The following is a description of a gene set: A general defect of GF K/BxN T cell proliferation response toward antigen motivated us to look for the impairment in GF K/BxN T cells that might leads to the low Ab production and reduced disease phenotype seen in GF K/BxN mice. To find the difference between GF and SPF K/BxN T cells in a broad and non-biased fashion, we performed gene-expression profiling of these cells using microarrays. studied in species Homo sapiens Human Gene Set: GSE22140_HEALTHY_VS_ARTHRITIC_GERMFREE_MOUSE_CD4_TCELL_DN from publication Wu HJ, Ivanov II, Darce J, Hattori K, Shima T, Umesaki Y, Littman DR, Benoist C, Mathis D (PMID 20620945) Genes down-regulated in CD4 T cells under germ free conditions: healthy versus arthritis (KRN model)., and this is the list of marker genes: P2RX4, BLVRB, ZFHX3, ILF2, PAF1, STAB1, INSIG1, PTOV1, ATP6V0D1, IRF1 (NCBI Gene Id 96501), C15orf39, EZR (NCBI Gene Id 7430), NAPA, TECR, PIM1, HOMER3, TNF, ZNF134, ABHD14A, FURIN, CD99, SLC7A11, LMNA, BATF, PLTP, GEM, S100A4, LGMN, BCAP31, HIVEP2, PHLDB1, SRSF2, GOSR2, MIR22HG, CCL3, HSPA1A, TNFAIP2, PDGFB, PPP1R15A, TRAF1, IL1B, TIMP2, RBM4, MAP4K4, NPC1, ZNF200, LCP2 (lymphocyte cytosolic protein 2), IER3, CCL8, RNASE1, IFI44, UAP1, FOLR2, OASL, SLC3A2, RPN1, ELOC, RPN2, CRIP1, IL7R, TGFA, SERPINB2, VSIG4, TUBB2A, RNF19B, TUBB4B, GPR107, FYN, ABL2, SH3BP5, CLIC1, PTX3, TP53BP2, TGFBI, ADAM19, ATRN, APLP2, PPIF, CLEC11A, SNN (stannin), DNAJC8, AK4, MTSS1, CCR1, ICAM1, COMT, HMOX1, CDKN1A, LGALS1, F13A1, HSP90B1, STX2, SLC7A8, NID1, TEX30, SDS, TLR2, RPS24, CCL4, DUSP5, SERPINE1, CTSL, PNP, TRIB1, STX4, WTAP, DNMBP, BIN1, DOCK10, THBS1, CTSZ, UBE2H, TPD52L2, EIF4A3, TNFRSF9, MRC1, PMAIP1, TCP1, CXCL1, CPQ, APBB3, NCOR2, TIMP1, PRPF4, CD47 (NCBI Gene Id 961), P2RX7, ATP8A1, BTG2, VNN2, GPNMB, TXNRD1 (NCBI Gene Id 7296), TUBB4A, MAP2K3, MX1, KRT10, ELL2, MYO7A, CCL7, TRIM25, IFIT2, SH3GL1, EMP1, MAN1A1, KLF6, YWHAZ, MSC, VASP (vasodilator stimulated phosphoprotein), HMGA1, DUSP2, TEX261, FCGBP, UPP1, TNFSF14, NQO1 (NCBI Gene Id 4834), FUS, LAIR1, RGS16, SERTAD2, OAS2, RENBP, GNA15, SERPINB8, KANK1, CLN3, CREM, CTSK, PMP22, RBMS1, CALM3, HLX, BCAT1, DENND4A, RGS1 (regulator of G protein signaling 1), RAB5C, PTGER4, NFKB2, ERGIC3, TNFRSF1B, TNFSF8, IGF1, IRF8, GCLM, SMURF1, NFKB1, SGTA (NCBI Gene Id 6449), TNFRSF11A, EMP3, SECTM1, GET3, PTP4A1, CD163 (NCBI Gene Id 9332), SLC2A3, SELENOP, CAPN2, XBP1, FCGR2A, RPS6KA2, CGRRF1, IFIT3, FERMT2